Given this list of marker genes SPECC1L, GRIP1, FRAS1, CYP19A1, NR3C1, CD96, FREM2 (FRAS1 related extracellular matrix 2), here is a description of the gene set: Hermaphroditism refers to a discrepancy between the morphology of the gonads and that of the external genitalia. In female pseudohermaphroditism, the genotype is female (XX) and the gonads are ovaries, but the external genitalia are virilized. Human Gene Set: HP_FEMALE_PSEUDOHERMAPHRODITISM Female pseudohermaphroditism studied in species Homo sapiens